The following is a description of a gene set: species: Homo sapiens Human Gene Set: VALK_AML_CLUSTER_7 Top genes from cluster 7 of acute myeloid leukemia (AML) expression profile; 61% of the samples are FAB M1 or M2 subtype. from publication Valk PJ, Verhaak RG, Beijen MA, Erpelinck CA, Barjesteh van Waalwijk van Doorn-Khosrovani S, Boer JM, Beverloo HB, Moorhouse MJ, van der Spek PJ, Löwenberg B, Delwel R (PMID 15084694) BACKGROUND: In patients with acute myeloid leukemia (AML) a combination of methods must be used to classify the disease, make therapeutic decisions, and determine the prognosis. However, this combined approach provides correct therapeutic and prognostic information in only 50 percent of cases. METHODS: We determined the gene-expression profiles in samples of peripheral blood or bone marrow from 285 patients with AML using Affymetrix U133A GeneChips containing approximately 13,000 unique genes or expression-signature tags. Data analyses were carried out with Omniviz, significance analysis of microarrays, and prediction analysis of microarrays software. Statistical analyses were performed to determine the prognostic significance of cases of AML with specific molecular signatures. RESULTS: Unsupervised cluster analyses identified 16 groups of patients with AML on the basis of molecular signatures. We identified the genes that defined these clusters and determined the minimal numbers of genes needed to identify prognostically important clusters with a high degree of accuracy. The clustering was driven by the presence of chromosomal lesions (e.g., t(8;21), t(15;17), and inv(16)), particular genetic mutations (CEBPA), and abnormal oncogene expression (EVI1). We identified several novel clusters, some consisting of specimens with normal karyotypes. A unique cluster with a distinctive gene-expression signature included cases of AML with a poor treatment outcome. CONCLUSIONS: Gene-expression profiling allows a comprehensive classification of AML that includes previously identified genetically defined subgroups and a novel cluster with an adverse prognosis., and this is the list of marker genes: SPTB, HBBP1, TRIM10, RAP1GAP, SLC6A8, TPM1, TAL1, RHAG, DNAJC6, SELENBP1, RHCE, PDZK1IP1, GYPE, HBZ, ANK1, OSBP2, KCNH2, GDF15, FAXDC2, TNS1, EPB41, KEL, SLC2A1, GAPVD1, MYL4, CLCN3, SLC6A9